The following is a description of a gene set: Human Gene Set: HP_REDUCED_FACTOR_VII_ACTIVITY Reduced activity of coagulation factor VII. Factor VII is part of the extrinsic coagulation pathway, which is initiated at the site of injury in response to the release of tissue factor (fIII). Tissue factor and activated factor VII catalyze the activation of factor X. species: Homo sapiens Reduced factor VII activity, and this is the list of marker genes: GGCX, AHCY, VKORC1, F7, SLC37A4